Given this list of marker genes Enpp7, Smpdl3a, Smpd1, Nsmaf, Smpd2, Smpd5, Smpd4 (NCBI Gene Id 77626), Smpd3, Smpdl3b, Eed, Stx4a, here is a description of the gene set: Mouse Gene Set: GOMF_SPHINGOMYELIN_PHOSPHODIESTERASE_ACTIVITY Catalysis of the reaction: H2O + sphingomyelin = ceramide + choline phosphate + H+. studied in species Mus musculus